Given this list of marker genes Mcub, Pax7, Six4, Selenon, Mstn, Megf10, Nfix, Snhg15, Mylk2, Klf5, Akirin1, Kat8, Cdon, Ephb1, here is a description of the gene set: Mouse Gene Set: GOBP_SKELETAL_MUSCLE_SATELLITE_CELL_DIFFERENTIATION species: Mus musculus The process in which a relatively unspecialized cell acquires specialized features of a satellite cell.